Given this list of marker genes CAV3, C3AR1, TAPBPL, BDH1, ATP2B2, EN2, SLC37A2, C8orf82, KRT25, KLHL10, CALCOCO2, LRRC10B, CDK20, DDX3Y, TP53BP2, ASCL3, ARHGAP32 (Rho GTPase activating protein 32), ZNF746, PPM1H, MPL, AMACR, DHRSX, CDT1 (chromatin licensing and DNA replication factor 1, NCBI Gene Id 81620), VSIG1, KLK5, CRHR1, PLPPR4, CCL19, ALS2, EFNA4, GZMM (granzyme M), TMC7, USP36, PTS, NOA1, PLAC8, PRSS56, CCNB3, CD5L, TMEM179, RSPO1, SLC26A1, IL15, ZNF418, PSD2, CA10, VARS2 (valyl-tRNA synthetase 2, mitochondrial), VPS53, C1orf159, PF4, NOL9, GZMH, KRTAP11-1, CADM4, PRR32, AGTR1, LMAN2, SLC12A5, FECH, VNN2, SCHIP1, NECAB3, SNX1, MC2R, WDR54, TRIM72, VGLL3, IPO11, PIR, CIB4, SNX24, GPR107, RNASE1, HOOK1, TRIM69 (NCBI Gene Id 400368), FREM1, RAB39A, DNAH8, PRR16, SPACA4, FLVCR2, HNF1A, CADM1, WASF3, BCL2L14, ENPP3, SERPINA10, NR6A1, BFSP1, ABCA9, RGS11, SYNC, PTPN18, ADAMTS4 (NCBI Gene Id 9507), MMP23B, NECTIN2, PDIA4, IL27RA, SLC16A14, TMEM51, GDF15, KRTAP8-1, FBXO17, PCDH9, ISCU, MCOLN3, KLHL35, LHB, CCDC198, FEN1, POLD3, RACK1, AKR1C3, BCAR1 (BCAR1 scaffold protein, Cas family member, NCBI Gene Id 9564), PRND, NOXO1, MSRA (methionine sulfoxide reductase A), FAM20C, RHOBTB3, CLRN3 (clarin 3), NFRKB, ZNF598, DNAH6, SYCP2, ATP13A1, TRMO, SLC8B1, CYP17A1, PGP, KRTAP4-12, TMEM79, POC1A, TEX13A, SMYD5, ANGPTL2, MCOLN2, MCTP2, FIG4, EYA4, ATP6V1B1, NGF, GDF10, AZIN2, RFX5, SHOX2, LYSMD2, NOSTRIN, ZMAT5, XDH, PCSK7, PRTG (protogenin), CRYBG2, SV2A, FBP2, CTSE, SETDB2, H2AC18, IFT56, DHRS11, C5orf46, RFC2, NALCN, C2CD4B, KCNG2, HTR1D, THEMIS, IDO2, CFAP70, NXPE4, EFEMP1, DLL4, CASP7, COL4A2, AKAP4, ZNF689, SLC4A8, ACVR2B, SPATA16, FAM98C, PLXNB2, SAMD10, CKB, NPRL2, FOXP2, GPR83, NFE2L1 (NCBI Gene Id 6937), ITIH5, RRP9, MFSD12, GNGT2, MTBP, PRRG1, CCDC54, ZKSCAN4, APOA2, MED22, THBS4, PNKP, COMMD5, here is a description of the gene set: species: Homo sapiens Genes down-regulated in B lymphocytes: control versus stimulated by anti-IgM for 8h. Triggering of B cell receptors (BCR) induces a massive synthesis of NFATc1 in splenic B cells. By inactivating the Nfatc1 gene and re-expressing NFATc1 we show that NFATc1 levels are critical for the survival of splenic B cells upon BCR stimulation. NFATc1 ablation led to decreased BCR-induced Ca++ flux and proliferation of splenic B cells, increased apoptosis and suppressed germinal centre formation and immunoglobulin class switch by T cell-independent antigens. By controlling IL-10 synthesis in B cells, NFATc1 supported the proliferation and IL-2 synthesis of T cells in vitro and appeared to contribute to the mild clinical course of Experimental Autoimmune Encephalomyelitis in mice bearing NFATc1-/- B cells. These data indicate NFATc1 as a key factor controlling B cell function. from publication Bhattacharyya S, Deb J, Patra AK, Thuy Pham DA, Chen W, Vaeth M, Berberich-Siebelt F, Klein-Hessling S, Lamperti ED, Reifenberg K, Jellusova J, Schweizer A, Nitschke L, Leich E, Rosenwald A, Brunner C, Engelmann S, Bommhardt U, Avots A, Müller MR, Kondo E, Serfling E (PMID 21464221) Human Gene Set: GSE21063_CTRL_VS_ANTI_IGM_STIM_BCELL_8H_DN